The following is a description of a gene set: Reactome Pathway: Signaling by NTRK3 (TRKC) part of: Signaling by NTRKs species: Homo sapiens NTRK3 (TRKC) belongs to the family of neurotrophin receptor tyrosine kinases, which also includes NTRK1 (TRKA) and NTRK2 (TRKB). Neurotrophin-3 (NTF3, also known as NT-3) is the ligand for NTRK3. Similar to other NTRK receptors and receptor tyrosine kinases in general, ligand binding induces receptor dimerization followed by trans-autophosphorylation on conserved tyrosines in the intracellular (cytoplasmic) domain of the receptor. These conserved tyrosines serve as docking sites for adaptor proteins that trigger downstream signaling cascades. Signaling through PLCG1, PI3K and RAS, downstream of activated NTRK3, regulates cell survival, proliferation and motility.<p>In the absence of its ligand, NTRK3 functions as a dependence receptor and triggers BAX and CASP9-dependent cell death.<p>NTRK3 was reported to activate STAT3 through JAK2, but the exact mechanism has not been elucidated. NTRK3 was reported to interact with the adaptor protein SH2B2, but the biological role of this interaction has not been determined.<p>Receptor protein tyrosine phosphatases PTPRO and PTPRS (PTPsigma) negatively regulate NTRK3 signaling by dephosphorylating NTRK3. In addition to dephosphorylation of NTRK3 in-cis, the extracellular domain of pre-synaptic PTPRS can bind in-trans to extracellular domain of post-synaptic NTRK3, contributing to synapse formation., and this is the list of marker genes: GRB2, NTF3, HRAS, KRAS, IRS1, SOS1, NTRK3, SHC1, SRC, NELFB, NRAS, PLCG1, PTPRS, BAX, PTPRO, PIK3R1, PIK3CA